The following is a description of a gene set: studied in species Homo sapiens Human Gene Set: GOBP_APPENDAGE_MORPHOGENESIS The process in which the anatomical structures of appendages are generated and organized. An appendage is an organ or part that is attached to the trunk of an organism, such as a limb or a branch., and this is the list of marker genes: AFF3, EXT1, CYP26B1, RDH10, LARGE1, NFIA, HOXD10, NOTCH2, RUNX2, TBX4, NIPBL, ALX1, MYCN, TBX2, GRHL2, ERRFI1, CACNA1C, FGF4, VPS54, ZNF141, INTU, TBX3, WNT7A, NPR2, TBC1D32, HOXD13, LNPK, ZIC3, HOXA13, DYNC2H1, ARK2C, TFAP2A, BAX, HAND2 (NCBI Gene Id 9464), WNT5A, PCSK5, HOXA9, ZNF358, TRAF3IP1, TWIST1, IHH, IQCE, PBX2, ALX3, GNA12, LRP4, HOXA11, TULP3, SP9 (NCBI Gene Id 100131390), RSPO2, PRICKLE1, RARG, TMEM107, MED1, LRP5, PBX1, FBN2, TTBK2, MEGF8, BPNT2, FREM2, ZNF219, HOXC11, GJA5, CTNNB1, SOX9, BMPR1A, SEMA3C, FBXW4, MSX1, MAP3K20, FGFR1, NOTCH1, PKDCC, FLVCR1, SKI, TFAP2B, RECK, FGFR2, CREBBP, ECE1, OSR2, NOG, RARB, FGF8, DKK1, FGF9, WDPCP, PSEN1, TMEM231, IFT122, SALL4, PTCH1, FZD6, MYH3, CIBAR1, CHST11, CRABP2, EVX2, FRAS1, SHOX2, EN1, TP63, ATRX, LEF1, SMAD4, HOXD12, ALX4, WDR19, GLI3, MUSTN1, LMBR1, HOXD9, BAK1, GDF5, ZBTB16, HOXC10, CHD7, COL3A1, IFT52, IFT140, HDAC2, PLXNA2 (plexin A2), MBNL1, WNT3, SHH, ASPH, ALDH1A2 (NCBI Gene Id 8854), PITX2, RPGRIP1L, HOXA10, PITX1, OSR1, BMP4, MOSMO, DLX5, GPC3, COL2A1, COL6A1 (collagen type VI alpha 1 chain), TBX5, PRRX1, GREM1, B9D1, HDAC1, ACD, FGF10, BCL2L11, SFRP2, C2CD3, MSX2, SP8, MKS1, SALL1, BMP7, TGFB2, DLX6